Given this list of marker genes MMP8, UBE3A (ubiquitin protein ligase E3A), NPL, DLG4, THBD, DDIT4, FANCC, PTPN5, ECE1, UGT2B10, POU2F3, KCNJ11, ACLY, CAMP, AP1AR, NQO1, ELAVL4, SERPINE2, SLC6A18, SRCAP, FGF2, ST6GALNAC3 (ST6 N-acetylgalactosaminide alpha-2,6-sialyltransferase 3), SERPINB2, CTPS1, NOTCH2, NADK, BMPR1B, EXOSC8, CCT6B, ST8SIA3, SLC22A5, KLF10, B4GALT6, KRT17, TTR, IL15, STK11, FAM216A, PIM3, HNF4A, CRYGB, SLC44A1, HBG2, RBM4, SLC30A3, DNM1L (NCBI Gene Id 692222), AIP, CCR5, SRSF2, TNFRSF4, H6PD, CPLX1, ASPM, PPFIA4, CNGA3, COL11A1, MRPL14, FRMD6, YES1, EXOSC5, ZSCAN26, ZNF600, AGAP1, HOXB4, SOX11, APOE, KDELR1, LRG1, RBM17, FZD2, NOTCH1, ADA, TMEM40, WDHD1, UBXN11, SLC7A1, FOXA2, SUPT6H, RAB33A, RAE1, TBX15, GPN1, FLNB, CXADR, S100A16, ZYG11B, AGL, CANX, TGFBI, ITGA8, CBFB, TUBA8, KLRG1, CALR, RNF14, ADGRG3, ZIC4, RHOD, MX1, ADAM7, TXNL4A (thioredoxin like 4A), CYP2C19, BAAT (bile acid-CoA:amino acid N-acyltransferase), FBN1, ADCK1, STAG2, SLC22A4, IKZF2, TMEM176B, SLC38A4, RFC3, SGTA, GLIPR2, SERPINA12, SEMA4B, TAT, MYL6, ITGA7, SPRR2A, CTTN, ZRSR2, NDUFS6, PHGDH, VAX1, ARID3A (AT-rich interaction domain 3A), MRPL55, TXNRD3, GABRA1, COL6A2, CTSG, HGSNAT, FN1, RNF123, ANGPTL4, FDXR, RALA, CDH11, HDAC7, PSCA, RPL39, ORC1, FAAH, SRSF7, GSTM3, CAMK2A, ATP6V1H, CAPN5, ENPP1, KRTAP19-5, ZNF292, SDF2, PSMD5, SLC10A3, UPP1 (NCBI Gene Id 7378), CD86, NME1, HNRNPH2, MT3, DCC, IDH3B, PEPD, ELF3, LGI4, MTMR9, MAP4K4, LAMB2, RGS2 (regulator of G protein signaling 2), SALL4, PTER, MKRN3, ANK3, SPRED2, WDFY2, LRPPRC, S100A6, ABCB9, PRKAR1B, RNF114, DXO (decapping exoribonuclease), CEL, ZDHHC5, BCAS3, ENC1 (ectodermal-neural cortex 1), INTS7, TSC1, KRTAP20-2, POLR1A, TUBA1A, LTBP2, NCK1, PLA2G4F, GLRA1, SH3GLB1, SEL1L2, ANKH, LRBA, AATK, SNX9, PAX9, BCL2, here is a description of the gene set: from publication Yosef N, Shalek AK, Gaublomme JT, Jin H, Lee Y, Awasthi A, Wu C, Karwacz K, Xiao S, Jorgolli M, Gennert D, Satija R, Shakya A, Lu DY, Trombetta JJ, Pillai MR, Ratcliffe PJ, Coleman ML, Bix M, Tantin D, Park H, Kuchroo VK, Regev A (PMID 23467089) studied in species Homo sapiens Human Gene Set: GSE43955_TH0_VS_TGFB_IL6_TH17_ACT_CD4_TCELL_60H_DN Genes down-regulated in CD4 T helper cells (60h): Th0 versus TGFB1 and IL6. Despite their enormous importance, the molecular circuits that control the differentiation of Th17 cells remain largely unknown. Recent studies have reconstructed regulatory networks in mammalian cells, but have focused on short-term responses and relied on perturbation approaches that cannot be applied to primary T cells. Here, we develop a systematic strategy – combining transcriptional profiling at high temporal resolution, novel computational algorithms, and innovative nanowire-based tools for performing gene perturbations in primary T cells – to derive and experimentally validate a temporal model of the dynamic regulatory network that controls Th17 differentiation. The network is arranged into two self-reinforcing and mutually antagonistic modules that either suppress or promote Th17 differentiation. The two modules contain 12 novel regulators with no previous implication in Th17 differentiation, which may be essential to maintain the appropriate balance of Th17 and other CD4+ T cell subsets. Overall, our study identifies and validates 39 regulatory factors that are embedded within a comprehensive temporal network and identifies novel drug targets and organizational principles for the differentiation of Th17 cells.